Given this list of marker genes Anxa2, Tmem97, Pcsk9, Ldlrap1, Arv1, Scp2, Acacb, Abca12, Abca2, Nus1, here is a description of the gene set: Any process that modulates the frequency, rate or extent of the directed movement of lipids within cells. studied in species Mus musculus Mouse Gene Set: GOBP_REGULATION_OF_INTRACELLULAR_LIPID_TRANSPORT